The following is a description of a gene set: Mouse Gene Set: GOBP_REGULATION_OF_TRANSLATION_AT_SYNAPSE Any process that regulates translation occurring at the synapse. studied in species Mus musculus, and this is the list of marker genes: Fxr1, Elavl4, Eif4a3l2, Eif4a3l1, Ngdn, Mtor, Cpeb2, Eef2k, Tent2, Eif4a3, Fxr2, Eif4e, Cpeb1, Fmr1, Cyfip1